Given this list of marker genes HSP90AA1, ERBIN, CDC37, ERBB2, here is a description of the gene set: studied in species Homo sapiens With respect to pertuzumab, a therapeutic antibody that block ligand-driven heterodimerization of ERBB2, ERBB2 R678Q is sensitive to pertuzumab, while ERBB2 V659E, ERBB2 G660D, ERBB2 G660R and probably ERBB2 Q709L are resistant. Reactome Pathway: Drug resistance in ERBB2 TMD/JMD mutants part of: Signaling by ERBB2 in Cancer